The following is a description of a gene set: species: Homo sapiens Human Gene Set: WP_SOMITOGENESIS_IN_THE_CONTEXT_OF_SPONDYLOCOSTAL_DYSOSTOSIS Somitogenesis in the context of spondylocostal dysostosis, and this is the list of marker genes: RIPPLY2, DLL3, HES7, NOTCH1, TBX6, MESP2, LFNG, DLL1, EPHA4